Given this list of marker genes ROMO1, LTF, CFHR5, F2, HRG, CFHR1, DEFB130A, CFHR2, SPAG11B, APOL1, CAMP, here is a description of the gene set: Human Gene Set: GOBP_CYTOLYSIS_BY_HOST_OF_SYMBIONT_CELLS The killing by an organism of a cell in its symbiont organism by means of the rupture of cell membranes and the loss of cytoplasm. The symbiont is defined as the smaller of the organisms involved in a symbiotic interaction. studied in species Homo sapiens